Given this list of marker genes SNRPF, CCT8, HPRT1, MIA2, LYPLA1, PMPCB, ATP13A3, SLC39A6, PRPS1, FBXO9 (F-box protein 9), SMARCC1, CBX3, BTF3, ZZZ3, ITPA, IDH3A, RMND5A, EIF4A3, HK2, THAP9-AS1, ZC3H14, DDX10, ZMPSTE24, GARS1, EIF3A, BLMH, ATP5F1C, PNO1, IPO5, HNRNPA1, EIF4E, SERBP1, DDX1, ADSS2, PGAM1, ACP1 (acid phosphatase 1), SERHL, U2AF1, COPS2, EI24, LDHB, AASDHPPT, ACVR1B, HDAC2, TXN (thioredoxin), NUFIP1, PDIA6, PSMG1, PSMD14, YY1 (NCBI Gene Id 7528), KPNA2, DIMT1, HSPE1, CNBP, SLC16A1 (solute carrier family 16 member 1), UBA2, TARS1, MNT, FAM120A, ETF1, NUP58, NUP93, KDSR, EXOSC8, UBE2K, TOMM20, ISCA1, GNL2, TOMM70, CHERP, FH, PTGES3, TFAP4, CCT5 (NCBI Gene Id 22948), FASTKD2, EMC2, NOLC1, SRSF1, USP10, BUB3, CCT2, NUP210, UBE2N, ZC3H15, RABGGTB (Rab geranylgeranyltransferase subunit beta), POLE3, NUP153, RANBP1 (NCBI Gene Id 5902), YARS1, SMN1, PWP1, PUM3 (NCBI Gene Id 9933), FBXO21, CYCS, ALG8, ANP32B, SERP1, HSPD1 (NCBI Gene Id 56733), NR2F2, ATXN10, CEBPB, SEC13, ALX1, NGDN, TMX1 (NCBI Gene Id 81542), DDX19A, MAD2L1, DEAF1, TRIAP1, NDUFB6, IARS2, SLC25A17, DCTD, OTUD4, DARS1, CSNK1E, AUH, ACTL6A, XPOT, SLC3A2, G3BP2, NUP98, ZBTB11, SRSF8, RNF114, SSBP1, SARS1, MACROH2A1, DCUN1D4, CYP2A13, DNAJC2, TFAM, MRPL3, DHX9, COX11, EIF2S1, HIRA, MTHFD2, API5 (NCBI Gene Id 95494), ZNF330, TIAL1, NAE1, SSB, GLOD4, OAT, TGDS, IARS1, AFG3L2, RLIG1, YBX3, PFDN4, NOP16, RAN, TCERG1, UBE2G1, EPRS1, EEF1E1, MACIR, WRN, PRMT3, APP, here is a description of the gene set: from publication Schlosser I, Hölzel M, Hoffmann R, Burtscher H, Kohlhuber F, Schuhmacher M, Chapman R, Weidle UH, Eick D (PMID 15516975) Proliferation of higher eukaryotic cells is triggered by the proto-oncogene c-myc (myc), which is induced downstream of a large number of growth factor receptors. Myc, a basic helix-loop-helix leucine zipper transcription factor, transmits growth signals by up- and downregulation of target genes. The importance of Myc in growth control is well established. However, the number of growth control genes requiring Myc as an essential factor for regulation after mitogenic stimulation of cells is not yet clear. Here, we have studied the transcriptional programme of a human B-cell line, P493-6, in response to Myc and serum. P493-6 cells do not express the endogenous myc, nor is it induced by serum stimulation. Proliferation of the cells is dependent upon both the expression of a tetracycline-regulated myc gene and serum stimulation. Using DNA microarrays, expression profiling was performed following stimulation of cells with serum, with Myc, or with both. We observed serum regulation of >genes. A number of these genes were synergistically or antagonistically regulated by Myc. Moreover, we identified >300 Myc-regulated genes that were almost unresponsive to serum. Gene ontology analysis revealed that a high proportion of Myc target genes are involved in ribosome biogenesis and tRNA metabolism. The data support our current notion that Myc is essential for the regulation of a large number of growth-related genes in B cells, and cannot be replaced by other serum-induced factors. Human Gene Set: SCHLOSSER_MYC_TARGETS_REPRESSED_BY_SERUM Cluster 7: genes up-regulated in B493-6 cells (B lymphocytes) by MYC and down-regulated by the combination of MYC and serum. studied in species Homo sapiens